The following is a description of a gene set: Genes predicted to be targets of miRBase v22 microRNA hsa-miR-6736-5p in miRDB v6.0 with MirTarget v4 prediction scores > 80 (high confidence targets). from publication Chen Y, Wang X (PMID 31504780) Human Gene Set: MIR6736_5P species: Homo sapiens, and this is the list of marker genes: TYRO3, IQSEC2, ZNHIT1, C6orf89, ZCCHC17, NRG3, USP14, EPM2A, DOCK7, DUOX1, ADH6, YIPF1, PRPF38B, GLYATL2, MFAP5, FGFR1, BEST1, TNPO3, MSRB2, OCM2, EXOC3L2, CAMK2D, NTS, CMTR1, PHLDB2, RAB27B, SLC35E2A, HSD17B4, CD37, QKI, OCM, DHFR, GEMIN5, KSR2, HDGF, RPE, SALL3, ETFRF1, SLC66A1LP, SUOX, FLI1, CRNKL1, SPTBN1, TBX5, MPDU1, OSBPL1A, LIPA